The following is a description of a gene set: studied in species Homo sapiens Human Gene Set: GOBP_CENTRIOLE_ELONGATION The centrosome organization process by which a centriole increases in length as part of the process of replication., and this is the list of marker genes: CEP295, CHMP2A, CCDC15, CENPJ, VPS4B, POC1B, CEP120, WDR90, PPP1R35, POC5, C2CD3